Given this list of marker genes DDR1, BAK1, UBE2F, TTC9B, MAN1A2, C2CD2L, PTGER2, PRR15L, SRRM4, PALLD, NTN4, AACS, LRP4, RFX4, EDDM3B, CELF2, BDH1, PLCB3, ESPN, SIAH2 (NCBI Gene Id 6478), RANBP2, PREP, CFAP298, PSMA1, ADTRP, HES1, BCS1L, CFB, SMPDL3B, ATG9B, PIKFYVE (phosphoinositide kinase, FYVE-type zinc finger containing), IDH3G, FAM234B, IPO7, TRIM6, FAM110A, MRPL16, IGFN1, TMEM256, MVB12A, DAPP1, SLFNL1, RPF2, PPP1R21, JAG2, BRK1, LPGAT1, OTUB1, GALM, DUSP3, PLEKHA5, ATP1B4, TMPRSS11A, IBA57, JTB, ZFYVE26, HSPA9, LY96, RAB33A, IFI35 (interferon induced protein 35), MFAP3, CRLS1, NUBP2, TENT5C, YARS2, PHLPP1, SPAG9, BIRC3, THOP1, PAK3, TTR, GTF2E2, MYORG, IL10RA, BEND3, KCNA2 (potassium voltage-gated channel subfamily A member 2), TTI1, PSMB5, CEP70, ATP6V0A2, C9orf50, SNX8, KAZN, ASAH2, SRP9, IFT172, AOX1, TAF1D, PTPRO, DELE1, CCDC88A, MKNK1, TXNDC11, AP2S1, PDIK1L, TANC2, NDUFC2 (NCBI Gene Id 4718), NDUFA12 (NCBI Gene Id 55967), FOS, MIR125A, UQCR10, PMEPA1, TAS1R1, SPATA31D3, ARL8B, LRRC14, CRYZL2P, TXNDC2, ZSCAN18, MYBBP1A, IMPA2, EDEM1, FAM118A, EDEM2, ASPSCR1, APOE, ANKRD49, SEC14L1, DUOXA2, RHBDF1, ROPN1L, IGSF9 (NCBI Gene Id 57549), ETV3L, KCNJ3, ATP5MC2, SPG11, METAP1, IL1B, WDR43, TPSAB1, VPS35, LYL1, COA5, SINHCAF, RXFP2, HAX1, PSMD7 (NCBI Gene Id 5713), EIF5B, RASIP1, ZP2, DDX51, FAM162B, LCLAT1, OLFM1, STARD9, ZCCHC3, OSGEP, CYRIB, BCAS1 (NCBI Gene Id 8537), SCTR (NCBI Gene Id 6344), ABHD6, CIDEB, GATB, MBOAT7, PGPEP1, SNAP25, ACACB, FEM1C, TMED10, CALM1, CD300C, MYOG, RRBP1, TRAPPC2L, CTTN, ARPC2 (NCBI Gene Id 220721), here is a description of the gene set: species: Homo sapiens Pioglitazone treatment of CD4+FoxP3- T cells transduced with Pparg and Foxp3 up-regulated a set of genes whose products have been implicated in lipid metabolism pathways. To verify the specificity of this treatment, we performed microarray analysis on Foxp3+Pparg1-transduced CD4+FoxP3- T cells after treatment with other PPARg agonists such as Rosiglitazone (TZD) and GW1929 (non-TZD). Human Gene Set: GSE37534_GW1929_VS_ROSIGLITAZONE_TREATED_CD4_TCELL_PPARG1_FOXP3_TRANSDUCED_UP Genes up-regulated in CD4 T cells over-expressing FOXP3 and PPARg1 isoform of PPARG: GW1929 versus rosiglitazone. from publication Cipolletta D, Feuerer M, Li A, Kamei N, Lee J, Shoelson SE, Benoist C, Mathis D (PMID 22722857)